The following is a description of a gene set: Human Gene Set: GOBP_EYE_PHOTORECEPTOR_CELL_DEVELOPMENT species: Homo sapiens Development of a photoreceptor, a sensory cell in the eye that reacts to the presence of light. They usually contain a pigment that undergoes a chemical change when light is absorbed, thus stimulating a nerve., and this is the list of marker genes: CRB1, GNAT2, SAMD7, RPGR, DZANK1, NTRK2, SAMD11, PDE6C (NCBI Gene Id 5146), CABP4, NRL, MYO7A, BBS4, GNGT1, CRB2, THRB, RPGRIP1L, RDH13, NR2E3, MFRP, NAGLU, VEGFA, FSCN2, RORB, TULP1, RP1, HCN1 (NCBI Gene Id 609), USH1C, DIO3, GNAT1 (G protein subunit alpha transducin 1), POC5, TH, THY1, RAB37, PRDM1, PRKCI, PAX6, CEP290, OLFM3, RPGRIP1